The following is a description of a gene set: species: Homo sapiens Human Gene Set: HP_GENITAL_ULCERS Genital ulcers, and this is the list of marker genes: KLRC4, TNFAIP3, IL10 (NCBI Gene Id 3586), HLA-B, BRAF, MEFV, TLR4, STAT4, IL12A-AS1, CCR1, UBAC2, C4A, MAP2K1, IL23R, DCLRE1C (DNA cross-link repair 1C), NRAS, IFNGR1, FAS, ERAP1, IL12A